Given this list of marker genes Mettl14, Virma, Wtap, Zc3h13, Cbll1, Rbm15b, Mettl3, Rbm15, here is a description of the gene set: Mouse Gene Set: GOCC_RNA_N6_METHYLADENOSINE_METHYLTRANSFERASE_COMPLEX studied in species Mus musculus A RNA methyltransferase complex that catalyzes the post-transcriptional methylation of adenosine to form N6-methyladenosine (m6A). In budding yeast, the MIS complex consists of Mum2p, Ime4p and Slz1p. In vertebrates, the complex consists of METTL3, METTL14 and associated components WTAP, ZC3H13, VIRMA, CBLL1/HAKAI and in some cases of RBM15 (RBM15 or RBM15B).